Given this list of marker genes SLC25A4, CHRNA9, ATRAID, PPBP, SLC17A6, SLC25A52, CHRNB4, HTR3C, FLVCR1, SLC3A2, KCNA4, KCNB1, RTBDN, RHBG, ATG9B, CRISP1, SLC9A5, ABCA10, NDUFB1, TMEM168, BLTP1, GLRA3, SLC49A3, ABCC11, NDUFA4, STAR, OSBP, NIPA2, CATSPER2, KCNK7, SPNS3, CPLX3, CNGA1, GABRB3, MFSD4B, APOC4, SLC8B1, SLC9A9, KCNJ4, SLC9A7, NDUFS1, ABCC3, CALHM1, AQP7B, PEX10, SLC14A1, TTYH2, PRF1, KCNA5, SLC25A20, ATP1A4, ABCC8, TMC4, GSTM2, SLCO1B3-SLCO1B7, ATP5F1E, CYBRD1, SLC4A5, ESYT1, SCN11A, SLC26A6, VTI1B, TRPA1, ATP5MC2, CACNA1E, ABCC9, KCNQ2, NEDD4L, TMEM87A, SLC24A2, GABRA5, SLC35A2, SLC12A4, SLC24A4, GJE1, PANX3, KCNA1, PRKG1, TPTE, SLC5A3, TMEM38B, ABCB11, ENSA, NDUFA12, SLC25A38 (NCBI Gene Id 54977), AQP8, SLC2A7, KCNE5 (NCBI Gene Id 23630), OPRM1, TAP1, GRIN3A, CACNB4, APOD, CACNA1A, SLC6A15 (NCBI Gene Id 59276), SNCA, GRIK3, GABRB1, MT-ND1, LRRC8A, ABCA7, TTPA, BCL2L1, ANO1, GLRX, LRP2, GJB6, AQP11, CACNA1B, ATP6V1G1, BEST1, ABCB5, MT-ND6, KCNK2, TMEM241, KCNS2, SLC4A11, ATP8A1, TMCO1, CLN3, SLC25A29, KCNG3, PEX12, NDUFA9, CAV3 (NCBI Gene Id 859), SLC25A15, NPY2R, SLC7A5P1, SLC6A13, PTPN3, KCNH2, FXYD7, RHD (NCBI Gene Id 6007), COX5B, TOMM20L, REM2, APOB, PEX6, SEC63, NRXN2, SLC17A5, ATP8A2, NIPA1, OSBPL7, MT-CO2, SLC22A24, SLC35F1, TRPV1, MCUB, ATP13A1, STX7, BLTP3B, NDUFS3, ORAI1, SLC39A3, APOL3, NDUFS7 (NADH:ubiquinone oxidoreductase core subunit S7), OSBPL6, AP4M1, PEX14, SLC19A4P, MT-ND3, OTOP2, ABCG2, SLC7A11 (NCBI Gene Id 23657), ABCC5, CACNB1, SCNN1B, SLC25A32, SLC8A1, SLC6A19 (NCBI Gene Id 8062), CACNA1H, KCNV1, SCN2B, ARPP19, SLC39A13, FGF12, TIMM29, ABCG8, SLC7A2, SLC35A3, RANGRF, GJA10 (NCBI Gene Id 84694), ANO5, TRPM5, NDUFA6, SLC30A9, TMEM184B, RHCE, ADRB2, KCNMB2, SLC38A2, SLC4A2, KCNJ5, ABCA6, GRIK2, COX7A1, SLC9A1, UQCR10, SLC27A2, NALF1, SCN7A, SLC27A5, CDH17, CYBB, TRPM3, OSBPL8, SLCO5A1, ATP6V1B1 (NCBI Gene Id 525), CATSPER4, ATP6V1E1, P2RX5, FGF11, BCL2, NDUFB6, DNAJB2, STX1A, RASA3, SLC44A5, CHRNB3, SLC22A15, SLC39A5, GABRA1, FHL1, SLC2A9, ANO6, ATP6V0E2, GRINA, BEST4, RASA1, PRKACA, XKR4, SLC2A8, SLC46A3, SLC38A8, SLC29A4, SLC25A25, SCP2, NCS1, STARD5, CLPTM1L, SLC40A1, PKD1L3, COX8A, SLC38A1, P2RX4, ATP13A4, FXYD6, ATP6V0E1, SLC9B1P1, CLIC6 (NCBI Gene Id 54102), CACNG4, MIP, SLC9A3, SLC51B, SLC9A2, FABP4, APOE, CIDEB, FLVCR2, SLC37A1 (solute carrier family 37 member 1), KCNMA1 (potassium calcium-activated channel subfamily M alpha 1), ATP13A3, SLC25A45, SLC2A13, KCNMB3, AZGP1, KCNK4, VMP1, SLC16A6, BSND, SLC4A1, AQP7, OSCP1, SLCO4A1, SLC6A9, SLC18A3 (NCBI Gene Id 6572), CALHM5, GPR89A, PLP2, SLC16A12, SLC38A6, AQP4, SLC27A4, SLC52A2, KCNK17, NDUFA3, KCNQ5, SLCO4C1, CLCN5, KCNJ8, SLC16A2, TMPRSS3, BCL2A1, TOMM7, GABRQ, CACNG3, CLIC3, SLC4A8, TIMM23B, GJA8, KCNF1, FKBP1A, ANO9, CHRNA5, MT-CO1, TMC3, SLC24A3, KCNJ6, SLC25A37, BEST2, SLC47A2, SLC35B1, SLC16A10, ABCG1, OSBPL3, SLC5A2, NPY, GABRB2, ABCA8, XKR9, CNGA3, SLC1A7, MT-CYB, KCNG2, ATP4A, GET3, TMEM135, TRPC7, GEM, SV2B, SLC19A1, SLC35C1, FLNA, KCNQ3, SLC7A1, GJC2, SLC30A1, PEX2, UQCRFS1P1, HCN2, NDUFS4, TMEM165, TMC5, ATP8B3, KCNK9, TPTE2, SLC7A3, SLC15A1, KCNK1, SLC10A2, TMBIM1, SLC45A3, STARD7, CACNG5, TMEM63B, SLC31A2, AKT1, CNNM1, SLC34A3, SLC6A12, SLC7A5, TMC8, SLC25A1, GPM6A (NCBI Gene Id 2823), PITPNA, DMAC2L, TOMM40L, KCNA10, PLTP, PKD2L2 (NCBI Gene Id 27039), TRPM7, SLC5A6, SLC25A28, CABP4, PRELID1, SLC24A1, ATP11A, CACNA1S, GJD3, CLCNKA, SLC13A2, SLC34A2, AKAP9, SLC45A1, GABRE, SLC22A23, TSPO2, SLC25A48, AQP3, SLC39A11, SLC35D3, TTYH3, SLC39A10, FXYD6P3, ATP5F1D, LRRC38, KCNH5, SLC35D2, SLC25A27, ABCC10, KCNH6, DPP10, DPP6, AQP12A, GABRA2, FXYD4, ATP6V1B2, PCSK9, SLC6A4, AQP12B, KCNJ11, PKD2, KCNJ12, PDE4B, KCNV2, SFXN3, PLEKHA8P1, AQP2, GM2A, GSDMC, CYC1, ARV1, MT-ND5, KCNK15, IGF1R, SLC26A11, CFHR4, OSBPL9, ATP2B1, PLN, SCN9A, ATP1A1, NDUFA7, TMEM63C, SLC25A51, MFSD3, ATP2A1, CLCN6, SLC43A1, CLIC2, GHITM, SLC25A10, SLC39A9, SLCO1B1, TMEM120B, MICU1, NALCN, SLC26A8, MFSD4A, ORAI3, GRAMD1B (GRAM domain containing 1B), MT-ATP6 (mitochondrially encoded ATP synthase membrane subunit 6), ATP6AP1, ATG2B, SLC5A1, STIM1, SLC35C2, CACNG7, GABRG1, CLCNKB, RSC1A1, GSDMD, SLC45A2 (NCBI Gene Id 51151), PACSIN3, BLOC1S3, SCN2A, ABCB8, SLC25A14, PRELID3B, KCNH8, SLC22A16, SLC26A1, TMEM63A, ATP6V1E2, SLC25A13, SLC25A17, ATP6V0A2, FAIM2, SLC30A7, VDAC1, KCNIP2 (NCBI Gene Id 30819), TRPV2, SLC26A10P (NCBI Gene Id 65012), SLC44A2, SGK1, GSDMB, BNIP1, SURF1, SLC22A31, SLC30A2, SLC38A11 (solute carrier family 38 member 11), CHRNB2, SLC36A3, AMIGO1, NDUFB7, SLC24A5, ATP8B2, NDUFC1 (NCBI Gene Id 4717), COMMD1, ABCB10, SLC39A12, FGF14, SLC38A5, KCNJ3, KCNAB3 (potassium voltage-gated channel subfamily A regulatory beta subunit 3), ATP1B2, SLC2A10, VAMP8, SLC22A5, KCNIP3, GPLD1, CACNG2 (calcium voltage-gated channel auxiliary subunit gamma 2), CABP5, COX7B, TMEM38A, HCN1, KCNK13 (potassium two pore domain channel subfamily K member 13), SLC1A6, CEACAM1, BAX, CLTRN, SLC22A8 (NCBI Gene Id 9376), SLCO1A2, ATP6V0A1, KCNG1, CLDN15 (NCBI Gene Id 245814), SFTPA1, SLC9B2, MFSD12, GRIA4, CNGA2, ABCB1, ABCC4, TSPO, OSBPL5, FXYD3, LAMP2, LRRC8B, SLC30A5, SUMO1, TSPOAP1, GJC3, MFSD14CP, SLC25A5, KCNA7, SLC8A3, TSPAN13, KCNC3, ITPR3, ANO4 (anoctamin 4), ABCA13, ATP5MG, NOS1, OCA2 (NCBI Gene Id 4948), KCNS1, CLDN10, ASIC5, SLC16A13, SLC17A7, SLC31A1, TPCN1, UQCRC1, TMEM37 (NCBI Gene Id 50627), ATP12A, TMC6, SLC6A8, SLC36A1, ATP6V1C1, SLC22A25, ATG2A, SCN4A, GJB1, ATP6V1G3, SLC22A9, ATP2B4, SLC10A4, GGA3, CLCN2, ABCC2, KCNH7, ATP9A, CAMK2D (calcium/calmodulin dependent protein kinase II delta), SLC10A5, LRRC26, ATP6V1F, SLC20A1, NDUFB4, SLC7A10, KCNN3, ATP6V0D2, ANKRD36C, C8orf44-SGK3, TRPC1, SCN1A, KCNA3, SCN3B, PHPT1, LRP6, SLC29A3, CACNA1C, SLC39A1, KCNH4, SLC28A1, CLDN2, NDUFB3, CACNA2D3, ATP4B, UQCRFS1 (ubiquinol-cytochrome c reductase, Rieske iron-sulfur polypeptide 1), KCND3, KCNAB2, NDUFS6, KCND1, ATP8B1, STING1, CLCN1, SLC37A2, KCNMB4, CPTP, SLC29A2, TCIRG1, ROMO1, SLC25A18, SLC22A18, CIDEA, KCNH3, ABCC12, SLC4A4, SERINC3, GLRB, MFSD14A, CYB561A3, SLC1A2, SLC7A6, SLC35F6, ATP6V1H, GJB5, GABRG2, SLC2A4, GABRA4, KCNK18, OSBPL1A, STRA6, SLC37A4, SLC38A9, SLC6A7, SLC49A4, ATP5F1B, PIEZO2, TMC1, SLC2A14, PLSCR1, PACC1, ATP10D, SLC22A6, KCNJ18, AKR1C4, FXYD1, CACNA2D4, CYB561D2, SLC9A8, NDUFA5, MCOLN1, SLC25A53, GJA1, TNFAIP8L3, SLC22A11, GRM3, SVOPL, CALHM4, GRIA1, APOM, MFSD1, GRIN1, SLC34A1, ABCA3, ATP5MC1, CNGA4, PANX1, HTR3A, MPC1, PKD1L1, CHRND, SV2A, SLC23A2 (NCBI Gene Id 9962), SLC25A44, KCNE1, SLC6A16, SLC26A4, TOMM22, SLC45A4, SLC38A10, SLC13A1, ANXA6, SLC16A11, SLC10A6, PIEZO1, TPCN2, CLCA2, KCNJ15, CLDN17, SLC22A10, NMUR2, SLC12A3, ATP5PB, CALM1, TIMM22 (translocase of inner mitochondrial membrane 22), SLC13A4, LRRC8E (leucine rich repeat containing 8 VRAC subunit E), SLC14A2, GPIHBP1, ATP1A2, ITPR2, CACNA1F, SLC9A4, RHAG, GABRR1, ATP5F1C, HPCAL4, GRIN2C, CHRNB1, MFSD9, ANKH, MTTP, SNAP25, ABCG4, MPV17 (NCBI Gene Id 4358), HVCN1, STX8 (NCBI Gene Id 9482), ITGAV, ANK3 (NCBI Gene Id 288), KCNE2, SLC4A10, SLC30A8, NDUFB2, SLCO6A1, SLC7A9, SLC35A5, SLC25A23, SLC25A33, AQP9, CAV1, ASIC4, SIDT1, SLC41A3, SLC29A1, ATP5PO, CACNA2D1, SLC22A14, LAMP1, SLC1A1, SLC18A1, SLC17A3, CHRNA10, SLC26A3, SLC17A2, NRXN1, CUL5, SLC26A7, ATP6V1C2, TRPV3, TMED10, CALM2, SLC9C2, CACNG6, NPC1, KCNN4, STOM, SLC35B4, STK39, SLC25A40, CNIH3, SEC61G (SEC61 translocon subunit gamma), SLC41A1, SLC18A2, GRID1, ABCB9, ATP1B4, SFXN5, NNT, KCNK16, TRPM1, COX5A (cytochrome c oxidase subunit 5A), SLC6A11, SLC26A9, ACTN2, SLC28A2, CLCN3 (chloride voltage-gated channel 3), CLCN4, SLC15A4, CHRNA2, SLC12A9, SLC6A6, SLC12A1, TMEM184A, NIPAL2 (NCBI Gene Id 79815), ATP1A3, KCNJ9, TRPM6, CHRNE, ABCA12, VDAC2, SLC6A3 (solute carrier family 6 member 3), CHRNA4, MMGT1, MT-ND4, MT-ND2, SLC25A3, SLC6A18, ATP2B2, LYNX1, ATP10A, TUSC3, SLC22A12, GJA9, SLC5A12, TIMM17A, SLC1A5, FABP3, GLRA2, SLC5A8, XPR1, ATP5MF, NIPAL1, FXYD5, SLCO2A1, TRIAP1, ABCD3 (ATP binding cassette subfamily D member 3), ATP6V0C, YWHAE, ATP5MC3, SLC35B3, PITPNB, ATP6V0A4, GRIA2, ACTB, KCNAB1, STARD4, SLC6A5, ATP1B3, SLC38A3, SLC2A5, CHRNA6, SCLT1, SLCO2B1, PLEKHA8, SLC52A3, KCNK5, CLIC1, SLC16A4, OSBPL10, ATP2A3, UCP1, APOA2, C2CD2L, GLRA1, MFSD10, PKD1L2, NPC2, KCNC1, MT-CO3, GJC1, SLC30A10, PITPNM1 (NCBI Gene Id 9600), ATP11C, ANO10, ADAMTS8, SV2C, SLC16A5, SLC16A8, OTOP1, ABCC1, GRIN2B, SLC7A13, SLC25A24, RHBDF2, NDUFC2, MPC1L, CCT8L2, CNNM2, GRIN2D, MPC2, SLC10A1, SNF8, SLC22A13, SLC44A3, RALBP1, ABCA9, SLC2A11, PLSCR2, SLCO1C1, TMBIM6, REM1, ZACN, MFSD8 (major facilitator superfamily domain containing 8), DRD2, TRPM8, P2RX7, WNK4, AQP5, PRKCB, SPNS2, ATP6V0D1, KCNJ1, SLC9A6, BCL2L10, ACE2, XKR8, CNGB3 (cyclic nucleotide gated channel subunit beta 3), SEC61A1, COX7A2L, SLC30A6 (solute carrier family 30 member 6), SLC25A41, NOX5, SLC41A2, ABCB6, ABCD1 (NCBI Gene Id 215), CYB561D1 (cytochrome b561 family member D1), SLC7A5P2, SLC5A4, SLC2A6, SLC25A19, TMBIM4, GLTPD2, ZDHHC13, SLC12A2, KCNJ16, TMEM94, SLC2A3, ATP11B, ABCD4, MTCO2P12, LRRC8D, APOA1, CLDN16, ABCA5, KCNIP1, KCNK6, BOK (NCBI Gene Id 84558), DRD4, MFSD5, CHRNG, SLC27A6, STIM2, LRP5, SLC12A5, SLC9B1, RFT1, SLC25A26, S100A6, NDUFS2, PLSCR3, NDUFA2, GJB7, MICU3, SLC5A5, GRIK4, KCNJ14 (NCBI Gene Id 3770), ATP5PD, NEDD4, APOL1, KCNJ2, RYR3, CATSPER3, KCNK12, LASP1, SLC43A2, FABP5 (NCBI Gene Id 92424), SLC26A2 (NCBI Gene Id 1836), PITPNC1, GJD4, FABP2, SLC22A17, SERINC2, SLC39A7 (solute carrier family 39 member 7), CABP1 (calcium binding protein 1), GJB3 (gap junction protein beta 3), SLC25A6, KCNG4, GPR89B, TNNI3, SLC48A1, KCNJ10, SLCO1B7, TMEM175, TMC2, SLC17A1, PRELID3A, COX4I1, KCNMB1, MFSD14B, RBP4, SLCO1B3, PLSCR4, TIMM23, RHCG, KCND2, ATP5F1A, CFTR, MRS2, ABCA1, KCNT1, HTR3B, GJD2, CTNS, APOA5, SLC38A7, SLC35E3, WNK3, ATP5PF, MT-ND4L, SLC37A3, HTR3D, GRIK5, PANX2, CALHM2, GC, SLC17A9, NIPAL3, ATP6V1A, ATP6V1G2, GJA5, SLC19A3 (solute carrier family 19 member 3), SLC27A1, CLCA1, SLC16A14, KCNK3, SLC36A4, SLC6A20, SLC25A12, SLC44A4, CALM3, OSBPL2, ASIC2, SLC28A3, STIMATE, P2RX1, CHRNA1, NIPAL4, GRAMD1C, MPEG1, ITPR1 (inositol 1,4,5-trisphosphate receptor type 1), P2RX3, SLC35E2A, GJA4, CIDEC, CLDN4, SLC7A8, SLC39A14, SLC6A17, SLC1A4, ATP1B1, SLC25A36, RYR1, ATP5F1EP2, NHERF1 (NCBI Gene Id 9368), AMBP, OXSR1, SLC12A7, SLC3A1, SLC5A10, SLC16A7, TRPC4, PEX1, SLC2A1, SLC23A1, SFXN4, FKBP1B, SIDT2, CETP, SLC66A1LP, SLC7A14, RACK1, UNC80, SLC25A21, OTOP3, RYR2, SLC13A3, KCNC2, SLC25A16, SCN5A, ABCA2, ANO3, PEX13, TOMM70, PDPN, SLC46A1, BCL2L2, GPD1L, ATP13A5, SLC2A12, SLC39A4, KCNE4, NDUFV1, FXYD2, KCNJ13, HFE, SLC7A4, SLC8A2, SLC12A8, CNNM4, ATP2C1, SLC17A4 (NCBI Gene Id 10050), GRID2, NALF2, GRIK1, TRPC4AP, SLC20A2, DCD, CACNA1D, SLC4A3, SLC2A2, SLC38A4, COX6B1, SLC4A9, SLC35E2B, SNTA1, TMEM30B, HCN3, CLCA4, CACNG1, CACNA1G, SLC11A2, GJA3, SLC18B1, NDUFB10, SLC15A2, PDZK1, GABRA3, GRIN2A, ATP5MGL, CACNB3, SCN1B, UCP2, LRRC52, SLC35D1, AQP6, SLC5A7, SLC33A1, TMEM184C, CACHD1, KCNIP4, SLC6A1, MFSD2A, SLC25A39, TMEM109, ABCD2, CLCN7, SLC23A3, M6PR, TMC7, TRPC6, CNGB1, SEC61A2, CABP2, SLC35E4, UQCRH, SFXN1, SLC47A1, CERT1 (ceramide transporter 1), TIMM17B, SLC30A3, SCN10A, SCNN1D, CHP1, ASIC1, CHRFAM7A, ANO2, SLC25A47, ATG9A (NCBI Gene Id 79065), AQP1, PKD2L1, HAMP, ATP2B3, ATP5ME, ANO8, SLC16A1, SLC44A1, TMEM266, SHOC2, GABRA6, SLC6A14, SHROOM2, SLC35A4, BAK1, ANK2, NDUFS5, CALHM6, TRPV6, TMEM144, ATAD1, TMEM120A, TRPV5, GABRD, SLC25A2, NDUFB8, SLC22A2, SLC50A1, SLCO3A1, SLC22A7, AQP10, NDUFA10, AGT, SLC10A3, MCU, CATSPER1 (NCBI Gene Id 117144), KCNQ1, ATP6V0B, ATP7B, KCNT2, ATP10B, WWP2, DLG1, MCOLN2, SLC15A3, CHRNA3, ATP8B4, SCN8A, P2RX6, SGK3, RRAD, SLC22A1, SLC25A22, APOF, KCNN1, NDUFB9, TMEM30A, HPX, NDUFV3, TMCO3, SLC35F2, CACNA1I, SLC66A1, PRELID2, ATP6V1D, KCNH1, PITPNM3, ATP9B (NCBI Gene Id 374868), KCNU1 (NCBI Gene Id 157855), BEST3, SLC25A11, SLC4A7, ATP7A, SGK2, CD36, ORAI2 (NCBI Gene Id 84917), ANO7, CALHM3 (NCBI Gene Id 119395), SERINC5, STARD3, GSDMA, KCNE3, UCP3, SLC25A30, HTR3E, P2RX2, SLC16A9, MFSD2B, SLC26A5, CACNB2 (NCBI Gene Id 783), SLC1A3, TTYH1, SCNN1A (sodium channel epithelial 1 subunit alpha), SCNN1G, ATP2C2, TOMM40, KCNB2, CCDC51, SORL1, ASIC3, ATP2A2, TRPM2, SPNS1, SLC5A9, SRI, SLC12A6, SLC35B2, TRPC5, SLC22A20P, KCNN2, GABRG3, KCNA2, SFXN2, ABCB4, SLC43A3, SLC16A3, TMEM41B, SLC39A2, ABCG5, SLC39A8, SCN3A, SLC32A1, PKP2, TRPC3, GRM2, SVOP, PGRMC2, MAGT1, FGF13, GRIN3B, SLC13A5, NDUFV2, ABCA4, GJB4, KCNC4, TOMM20, GABRR2 (NCBI Gene Id 2570), PCTP, YWHAH (tyrosine 3-monooxygenase/tryptophan 5-monooxygenase activation protein eta), GABRR3, SLC35E1, TMEM44, APOA4, SLC39A6, LETM1, TRPM4, MCL1, CLDN19, SLC5A11, ABCB7, GABRP, SLC25A31, TIMM8B, PSEN1, SLC10A7, PKD1, SLC25A42, CACNG8, GSDME, CHRNA7, TRPV4, ABCC6, KCNA6, SLC30A4, SLC19A2, SLC51A, MT-ATP8, SLC22A4, GRAMD1A, LMBRD1, ATP13A2, SLC22A3, SLC15A5, SLC36A2, CACNA2D2, GLTP, LETM2, MICU2 (mitochondrial calcium uptake 2), CLIC5, KCNK10, SLC17A8, NHERF4, TAP2, TMEM150C, SLC46A2, SLC7A7, SLC11A1, NDUFA1, LRRC8C, SLC35A1, CLIC4 (chloride intracellular channel 4), GJB2, PKDREJ, CLCC1, CNNM3, SLC6A2, PLSCR5, LRRC55, NDUFB5, KCNQ4, SLC9C1, PDE4D, KCNS3, SLC52A1, MCOLN3, PITPNM2, SCN4B, VDAC3, NDUFA8 (NCBI Gene Id 4702), HCN4, GRIA3, NDUFS8, SMDT1, here is a description of the gene set: Human Gene Set: GOMF_TRANSPORTER_ACTIVITY Enables the directed movement of substances (such as macromolecules, small molecules, ions) into, out of or within a cell, accross or in between cells. studied in species Homo sapiens